The following is a description of a gene set: species: Mus musculus Mouse Gene Set: GOBP_SYNAPTIC_VESICLE_RECYCLING_VIA_ENDOSOME Synaptic vesicle recycling where vesicles endocytosed via clathrin-coated pits re-acidify and refill with neurotransmitters after passing through an endosomal intermediate., and this is the list of marker genes: Itsn2, Btbd8, Itsn1, Ap3d1, Ap1s2, Gripap1, Rab7, Bcl2l1, Dnm1l, Myo5b